Given this list of marker genes KIF26B, DYNLRB1, KIF14, KIF18B, KIF2A, KIF2C, DNAH8, KIF19, KIF3C, KIF5C, DYNC1I1, KIF20B, DNAH9, KIF26A, KIF21B, KIF9, DNAH1, KIF21A, KIF5B, DNAH11, KIF13A, KIF4A, KIF11, DYNC1I2, KIF6, STARD9, DNAH7, KIF20A, DNAL4, KIFC3 (kinesin family member C3), DNAH6, KIF27, APPBP2, DNAH2, KIF1A, KIF24, KIF7, DNAH5, DNAH10 (NCBI Gene Id 55921), DNAH14, DNHD1, DNAI2, SMC3, KIF15, KIF12, DNAH12 (dynein axonemal heavy chain 12), KIF18A, KIF1B, KIF17, KIF23, DYNC1H1, KIF3B, KIF13B, CENPE, KIF3A, DYNC2H1, KIF22, DNAH17, KIF25, KIF1C, KIFC1, KIF2B, KIF28P, KIF5A, KIFC2 (kinesin family member C2), DYNLRB2, KIF16B, DNAH3, KIF4B, here is a description of the gene set: species: Homo sapiens A motor activity that generates movement along a microtubule, driven by ATP hydrolysis. Human Gene Set: GOMF_MICROTUBULE_MOTOR_ACTIVITY